The following is a description of a gene set: studied in species Homo sapiens Polymorphisms in nitrosamine metabolism, DNA repair, and immune response genes have been associated with nasopharyngeal carcinoma (NPC). Studies have suggested chromosomal regions involved in NPC. To shed light on NPC etiology, we evaluated host gene expression patterns in 31 NPC and 10 normal nasopharyngeal tissue specimens using the Affymetrix Human Genome U133 Plus 2.0 Array. We focused on genes in five a priori biological pathways and chromosomal locations. Rates of differential expression within these prespecified lists and overall were tested using a bootstrap method. Differential expression was observed for 7.6% of probe sets overall. Elevations in rate of differential expression were observed within the DNA repair (13.7%; P = 0.01) and nitrosamine metabolism (17.5%; P = 0.04) pathways. Differentially expressed probe sets within the DNA repair pathway were consistently overexpressed (93%), with strong effects observed for PRKDC, PCNA, and CHEK1. Differentially expressed probe sets within the nitrosamine metabolism pathway were consistently underexpressed (100%), with strong effects observed for NQ01, CYP2B6, and CYP2E1. No significant evidence of increases in rate of differential expression was seen within the immune/inflammatory pathway. A significant elevation in rate of differential expression was noted for chromosome 4p15.1-4q12 (13.0%; P = 0.04); both overexpression and underexpression were evident (38% and 62%, respectively). An elevation in the rate of differential expression on chromosome 14q32 was observed (11.3%; P = 0.06) with a consistent pattern of gene underexpression (100%; P < 0.0001). These effects were similar when excluding late-stage tumors. Our results suggest that nitrosamine activation and DNA repair are important in NPC. The consistent down-regulation of expression on chromosome 14q32 suggests loss of heterozygosity in this region. Genes down-regulated in nasopharyngeal carcinoma (NPC) compared to the normal tissue. Human Gene Set: DODD_NASOPHARYNGEAL_CARCINOMA_DN from publication Dodd LE, Sengupta S, Chen IH, den Boon JA, Cheng YJ, Westra W, Newton MA, Mittl BF, McShane L, Chen CJ, Ahlquist P, Hildesheim A (PMID 17119049), and this is the list of marker genes: ANKMY1, OR7E12P, UBL3, ADIRF, CFAP119, DNAH9, CIMIP2C, MRAP2, MAP6, SPA17, SCRN1, DNAH3, KRT4, RUNDC3B, SMIM22, PPIP5K1, TTLL10, TMCO6, CDC14A, ATP6V1D, LINC02288, DNAH1, COL1A1, DRC3, TUBBP5, DND1, ST3GAL3, CDC42BPB, DDAH2, ARMC3, PLAC4, PARVA, CRACR2A, PLEKHH1, CCDC69, SPTLC2, SGSM3, SLC13A4, TACC2 (transforming acidic coiled-coil containing protein 2), TP53INP2, TOM1, CLDN3, KCNJ15, NATD1, CD1C, GCHFR, SDCBP2, MINDY1, GRIN3B, RMDN3, TCP11, PKN3, CEACAM6, CHMP1A, CPPED1, CFAP73, KLHL6 (NCBI Gene Id 89857), ANKUB1, MYEOV, LINC01222 (NCBI Gene Id 102800316), AQP5, ATP6AP1-DT, CLMN, CD22 (NCBI Gene Id 933), TSNAXIP1, LRRC18, CIRBP, DUOX1, SLAIN2, CATSPER2, RNH1, PHYHD1, PRKAA2, SHLD1, LINC01821, RORB, ZBTB14, CRYBG2, MMP24, CERT1, CIMAP1B, DNALI1, FAM131A, NIPAL2, AGFG2, SAT1, CCDC13, YIF1B, KCNJ12, MTSS1, PGAP3, DEGS2, TMEM45B, KRT23, ARHGEF37, ADRB1, BCAR1, CLIP4, CIMAP3, POMGNT2, TPO, CFAP43, TPPP3, CRACDL, MPRIP-AS1, GPR162, SMIM6, PSKH1, PPIL6, TRMT44, CTSB, FAM149A, RDH10, IGHG1 (immunoglobulin heavy constant gamma 1 (G1m marker)), GOLGA2P5, C22orf23, GGT7, ALB, VAMP5, NBL1, ROPN1L, FKBP1B, EPPK1, LIAT1, CAND2, MAP1LC3A, TPRG1L, AFDN, CDC20B, CAMKK1, JDP2, CCDC181, SLC22A16, MSRA, ELF3, CXCL17, TPTE2P6, ZDHHC13, BCL2L15, GALNT14, POLR1HASP, RECQL5, MNS1, ATP6V0A4 (ATPase H+ transporting V0 subunit a4), GIRGL, FGF14, RASSF1, COQ4, PGM5-AS1, LYPD6B, NHERF1, VNN3P, SYTL1, VPREB3, UBTF, LRRC56, MYH4, TTC23L, MACROD2, DALRD3, ZNF703, MLPH, LINC00899, VILL, INAVA, STOM (NCBI Gene Id 2040), SNTN, APLP2, TNFAIP8L1, ZNF839 (zinc finger protein 839), MAOB, TBC1D22A, ENSG00000290731, PRSS22, BLID, CFAP126, IQUB, DIAPH2, C2CD4D-AS1, ENPP5, MLYCD (malonyl-CoA decarboxylase), TBC1D10A, CLEC4F, PPOX, CEP19, CYP2E1, YPEL3, GRM5, MIPEP, ABCA13, ABCC2, ARK2N, ATOSA, LRRC10B, IP6K1, STRBP, SMPD2 (NCBI Gene Id 6610), NSUN7, SCAMP2, CC2D2A, MUCL1, MEIS3P1, ANKRD9, CELF6, LYPLA2, OGG1, FUT2, ZNF445, GPT2, REEP6, EPHA2, LRRC27, SUSD6, PCDH1, USP4, WFDC21P, CAPN5, CBX7, PDZD2, SPRR1A, DEFB124, GAS8, CYP2F1, WDR17, CYSTM1, MUC4, SERTAD4-AS1, DHRS9, SPAG16, CFAP157, GJB1, ZC2HC1C, DMRT2, KALRN, CCDC190, CKMT1B, GIPR, CFAP46, ZNF542P, CD72, LINC00683, FARP2, ZNF844, TEKT1, HOPX, TMC5, MPL, USP51, ENSG00000280119, OSBPL6, WDR93, WWP2, SHANK2, LINC00963, CES1, BDKRB2, PAPOLA, KIF19, STOML3, SYTL5, STK11IP, C21orf58, WFDC2, LY6G6E, CWH43, FBXL8, ABHD2, LINC01770, ING2, CFAP95, CFAP47, NUP50-DT, DIO1, NR4A2, TTC6 (tetratricopeptide repeat domain 6), TREML2, MSANTD2-AS1, ARRDC2 (NCBI Gene Id 27106), NIPSNAP3B, IFTAP, ARSD, DIXDC1, TLE2, NINJ2-AS1, ARHGAP32, LIMK2, TSPAN6, SLC34A2, TMPRSS11D, SLC37A1, CCDC78, ZNF487, NEIL1, C16orf89 (chromosome 16 open reading frame 89), DNAH7, CEP164, SLC51A, CCDC12, RNU4-78P, MBTPS1-DT, CA5B, ATP2C2, SHISA8, ENSG00000258752, SERPINB3, MSLN, SPATA24, CLDN7, SERPINB2, PDLIM2, DELE1, TMEM154, OSBPL10, PDZK1IP1, FAM174A, MS4A15, FCMR, GSTA1, CD163L1, DUSP1, STARD9, CCDC80, HSBP1, MDS2 (NCBI Gene Id 259283), DNAH11, DAW1, MAP3K13, CFAP276, HSPB8, BTD, ENSG00000308109, NME5, OR2A4, PSENEN, EFHC2, HS3ST6, STX18 (syntaxin 18), TMEM120A, FBXL7, SYTL2, BACE2, ANXA1, DYDC2, NEBL-AS1, B3GALT4, TTC39C, BEND5, RASAL2, TTLL13, KRT40, WDTC1, APCDD1, SORT1, DNAH5, TMEM125, CTH, MMP15, CFAP298, DCTN1-AS1, LINC00592, ENSG00000271046 (novel transcript), TTC9, GAN (gigaxonin), TBC1D9, TNNC1, NHLRC2, FBXO36, EPS8L2, ASAP3, NIBAN3, CSTB, RIPK3, TEKT2, TMEM107 (NCBI Gene Id 84314), CCDC157, PNLDC1, C11orf97, DNASE1L3, PKHD1L1, CD55, NMU (neuromedin U), ALOX15, LINC02622, SLC16A5, RNU6-418P, S100P, ENSG00000238142, FCRLA, SIX2, SRD5A3, FOXN3, SPACA9, FAM153CP, SNORD123, MRPS31, CD180, SLC20A2, MAB21L4, CLDN10, CFAP45, CCDC60, ADGB, CMAHP, GOLGA2, RIIAD1, PAPOLA-DT, PCYT2, VTCN1, CHST9, KATNIP, WDR49, VWA3A, GIHCG (NCBI Gene Id 100506844), SEPTIN5, SLC16A7, SAXO4, RALGAPA2, MB, ADHFE1, HEY1, ZFYVE21, BCO2, TRIM7, KLHDC8B, CGN, HHLA2, SLC44A4, POLD4, KHDC1L, RINT1, C11orf71, STN1, SSUH2, HIPK1, CIZ1, MKS1, CFAP206, STK33, TMCO5A, VSTM2L, GPR182, PRUNE2, SYNE4, DNAJB2, ABCB1, CFAP74, EFCAB6, ZBBX, CH25H, CIB2 (NCBI Gene Id 404086), IFFO2, B9D1, NECTIN4, DCDC2B, TFF3, UNC5B-AS1, SPAG1, ACSM1, MAGED2, SCGB1A1, BICDL2, GNMT (glycine N-methyltransferase), S100A6, BAIAP2 (BAR/IMD domain containing adaptor protein 2), OR2A1-AS1 (OR2A1 antisense RNA 1), EPAS1, SLC16A9, DNAH10, CCDC146, SELENBP1, PGAP4, CHL1, KRT13, SH3D19, SAXO2, TMEM61, TMEM190, PLCE1, CDHR3, CFAP53, RABL2B, CHST6, SMPD3, CYB561D2, CARD14 (NCBI Gene Id 79092), KRT78, EFHD2, DENND6B, TEX26, P2RY2, CCDC88C, RHOBTB2, SYNE1, DNAH2, ARX, H2BC21, SPATA7, FOCAD, GSN, FAM216B, C15orf62, EIF4EBP3, AK9, ADSS1, CD79B, PPDPF, SLC46A3, TRIM55, DNAI3, LGALS7, CCDC148, TRNP1, C4BPB, DYDC1, LXN, ANKRD35, KLK10, WDR31, CALM1, EZR, PER1, TNFSF11, TMF1, SLC27A1, CASP9, SAP25, SAA1, KLHL41, SGMS2, MAK, PTPRO, MTF1, KRT80, ZNF667, AHNAK2, CIPC, VPS11, CLCA4, MICAL3, ME3, CPLX3, CD81-AS1, MMP24OS, CES4A, EXD3, ZNF439, SPATS1, AGBL4, LDLRAP1, SPINK2, PINK1 (NCBI Gene Id 65018), CXorf58, SPMIP6, CCEPR, GSTA3, DEF8, HEMK1, ALDH1L1, LINC00326, PDCD6IP, SYNPR-AS1, ASXL3, IL5RA, TAX1BP1, AGBL2, TRPM1, TNXB, KRT7, TNFRSF10D, UCP2, EPB41L4B, RHOU, C2CD2L, CYP2A6, CLIC6, HDAC5, ZNF295-AS1, CEACAM7, ALS2CL, CNGA4, EFCAB12, ASL, ENSG00000237773, DCST1-AS1, TM7SF2, PI3, SLC2A10, GNAQ, MASP1, DNAI2, DNAJA4, RGS14, ARG2, SMIM34 (small integral membrane protein 34), MYH11, ANXA2P2, CFAP221, ST6GALNAC1, TCEAL3, HOTTIP, SAMD15, NPHP1, CEP112, KLF8, IQCH, LRWD1, STIMATE, MGAM, IYD, TTC12, SPATA17, B3GALT5 (beta-1,3-galactosyltransferase 5), DNAAF1, SPAG8, CAPN9, SCUBE2, REEP1, PHACTR1, FAM153A, RGS8, PSMB8-AS1, E2F4, ZBED5-AS1, MOK, NEBL, STEAP4, AXDND1, OXTR, GDPD3, SNRK, PPP1R36, B3GNT7, TMEM256, SLC12A6, ACTL7B, SAPCD1-AS1, TCTN1, SUGT1P3, FAM209B, RPS6KA2, PLEKHS1, CAPN14, GFOD2, SYBU, ENSG00000253887, CAPS, DNAH6, RARB, SAT2, HFM1, LOXL4, CDKL1, FAM107B, IMPA2, LMO7, MFSD4A (NCBI Gene Id 148808), PTGDS, DCDC1, OR7E14P, RRAD, CCDC170, SLC24A4, CFAP61, UGCG, BCAS1, PLLP, AGR3, PIAS2, PIH1D2, LRRC4, ODF2L, IL18, EHD3, ZFAND2B, GSTZ1, WDR13, CROCC, PIP4P1, CLUAP1, ZNF214, ADH6, ATP13A4, PCP4L1, LCN2, RIBC1, NRXN3, MPHOSPH6, AHI1-DT, CETN2, KLK13, BACE1, RNF183, FECH, KCNMB2, LRRFIP1, LRGUK, TXLNB, BASP1, BDH1, CLDN8, RSPH1 (NCBI Gene Id 89765), MST1, TMEM40, WDR86-AS1, PYGL, LEFTY2, ACRBP, RIBC2, WFS1, PIAS3, MS4A1, DUSP22, SAA4, DYNLT5, MUC5AC, DZIP3, ABHD17B, DNAAF6, OR7E47P, DUSP26, ZSCAN31, HHATL, PPP1R16A, AGPAT2, PDE7B, GLIPR2, DENND2C, MVP, FMN1, IRAG1-AS1, SLC15A2, PRSS23, GLUL, MUC16, RSPH10B (NCBI Gene Id 285927), HECTD1, GOLPH3-DT, ELK3, TSGA10, GAPVD1, VWA8-AS1, NIBAN2, ARMC2, MOB3C, TPT1, POR, ALCAM, LIPH, PLAAT4, CKB, OR2A20P, CFAP210, TOGARAM2, CAPS2, ENSG00000265246, STAG3, ANKRD54, MAGIX, RNF103, PRRT3, C6orf132, PPP1R3C, MAP3K1, CCDC89 (NCBI Gene Id 220388), ABCC6, BCAN, METRNL, EPB41L1, RPSA2, ZNF784, BHLHE41, TMEM105, EVPL, KCNK6, DRC7, TSPAN1, CFAP69, ZSWIM5, QSOX1, CFAP58, GNAL, EFHB, LRTOMT, GRAMD1C, EFCAB2, NR2F2-AS1, POLR2A, ANKFN1, REXO1, PZP, CIITA, CFAP263, CADM4, MEIS1, FAM219B, MROH8, SORBS2, C9orf152, FBXL2, ZNF662, CRAT, DRC1, CYP2C8, ATP1A2, SMBD1P, SH3BGRL2, UST, ANKRD18A, MT1M, AKAP13, MDH1B, RSPH3, EXPH5, RHOV, PRR15L, C7orf57, LRRC23, POM121L4P, IGSF22, CDH12, MSI1, ZNF677, CALML4, BTBD7, MZF1-AS1, ZNF552, FAM184A, ZNF106, DICER1-AS1, ANXA9, CEP170B, RAB38, TMC4, DYNC2H1, IL20RB, DYNLRB2, CFAP92, BBOF1, SLC25A14, SERPINB6 (serpin family B member 6), MBOAT2, MEIS2, CLCN4 (NCBI Gene Id 4412, chloride voltage-gated channel 4), DMKN, MKX, BMPR1B, DUOXA1, CHP2, PCSK5, IFT46, ADORA1, ENSG00000270159, CCDC30, KCNE3, DOCK8-AS1, DTX4, RAB40B, DNAI7, FBLN7, P2RY1 (purinergic receptor P2Y1), SLC22A4, AMOTL2, BTG4, PCDHA9, BLK, CBY1, MAP1A, SPAG6, HMGCL, MYCBPAP, C6orf118, RIPOR2, FUT8-AS1, PPP1R13L, VPS9D1, EYA4, PEX11A, CASC2, FKBP6P2 (NCBI Gene Id 541473), LINC02846 (NCBI Gene Id 105376323), NEK11, PTPRT, ZNF599, ATP10B, TTC38, CIMIP6, TNS1, FUT6, JADE1, P4HTM, ADGRF1, PLEKHG2, DOP1B, SLPI, DIDO1, SPATA18, GNG7, ZER1, C4orf3, SYTL4, ACSBG1 (NCBI Gene Id 23205), CHRNA3, MYH14, RGS22, ADAMTS8, TMEM156, USP2, SMIM5, MYO1D, PXN, ERBB2, ZNF474, C22orf15, MBP, THRB, ST14 (ST14 transmembrane serine protease matriptase), ARMH4, CFAP96, ENSG00000235659, PER2, TTC7A, ZDHHC1, SLC22A18, PPARG, SERHL, VSIR, MYO5B, PINLYP, LZTFL1, PRDX1, SRPX2, DNER, CRIP1, ECM1, CA12, MLF1, FAXDC2, PTPRU, ADH1A, FRMD4B, PRKCD, MMEL1, LINC00939, EP300-AS1, PLXNB1, BBS9, CFAP107, NRAV, IFT56, CCDC39, NUMB, C15orf48, PTGR1, LPCAT4, DZANK1, SH3GL3, KIAA0513, TNFRSF19, CD19, IQCA1, SIX1, PCBP3, CCDC136, SERPINB4, FOXP1, SERPINB13, WFDC3, FAM83E, OSBPL2, ANKRD37, GNA11, DUOX2, RTEL1, FBXO34, CR2, ABLIM1, SNRPCP11, GRHL2-DT, MIR34B, MED16, SLC25A29, PLPPR3, TJP3, PITPNM1, C1orf87, MAP4K3-DT, MYZAP, FAM221A, SVEP1, GBP6, SCGB2A1, CACFD1, C10orf67, TTTY8, CPEB3, PHF1, ELL3, STK32C, TIMP4, CXXC5, GSKIP, HES1, ALDH1A3, CRY2, NFE2L2, IL20RA, GNE, HHEX, FAM229B, UPK1B, LCA5, CD1D, DHCR24, CCR6, UBAC2, KCNT1, FANK1, ASRGL1, SIGIRR, PIERCE2, PLAAT2, TCL1A, TMBIM1, GRK6, STIM1, ENSG00000293607, STPG1, ENKD1, RNF175, ZDHHC3, SERPINB1, TOR4A, GMDS, PITPNM3, OMG, MARCHF10, COL25A1, CFAP251, GNA14, MYOF, TPPP, ADARB2, CYP39A1, EIF1B-AS1, SPIRE2, RHPN2, SLC13A3, ZNF750, CFAP184, DGKD, MOSPD3, DNAJB13, CYP2B6, SLC6A6, ADH1C (NCBI Gene Id 126), CTNS, CFAP70, NT5C2, STK24, CCDC17, ZMYND10, STPG3-AS1, GPD1L, MAL, TGM1, ZNF185, PCDH20, LINC03086, ZNF853, ABLIM3, TADA2B, TSTD1, CFAP410, ALDH3A2, TUBB4B, DRD2 (NCBI Gene Id 91906), FBXO15, RALGPS2, SUNO1, LINC01186, ALDH3A1, SPATA4, ENTPD3, GUCY2C, DLEC1, CCL28, LINC00856, VSIG2, PIGR, CYB561A3, KLHDC7A, CACNA1I, CABCOCO1, NEK5, CFAP300, KATNB1, KNDC1, DHX32, FRAT1, LINC00467, KRT14, TIPARP-AS1, ROPN1, FCRL2, SLC35C1, CCDC160, ESPNL, IDNK, KLF5, DBP, CFAP91 (NCBI Gene Id 89876), PRKAR1A, DYNC1H1, TIRAP, C6orf89, ZNF709, LEKR1, DNAI4, DNAL4, RORC, DNAAF11, CFAP20DC, AMFR (autocrine motility factor receptor), GALC, KLHL32, DZIP1L, RAB37 (RAB37, member RAS oncogene family), DUSP18 (dual specificity phosphatase 18), WNT9A, CRACR2B, TRAF3IP1, IFT43, PLAC8, CIMIP1, CEACAM5, ABHD14B, SIK3, SPATA6, RBM20, AMIGO1, CLIC5, EPS8L1, DGCR2, VMO1, RBM24, CD40LG, CATSPERE, FAM90A1, RNASE4, ABHD12B, H2AC8 (H2A clustered histone 8), CST6, CAMK2G, SERTAD4, MIEF2, RORA, CLIC3, ZNF473CR, CCN2, TACSTD2, ZNF667-AS1, VTN (vitronectin), GCLM, ITPK1, MIR141, ZNF880, FGD2, CRYM, TCEA3, NAPRT, SCRN2, CPQ, PHLPP1, AHNAK, ENKUR, PWWP2B, KCNE1, OSCP1, BTC, RPS6KA3, DYNLT1, KCNQ1OT1, CYP4B1, NEK10, NF1, CBFA2T3, TRAK1, CNKSR1, PRKAR2A, TENT5B, AQP4, KLK12, BAG1, TTC16 (tetratricopeptide repeat domain 16), LITATS1, FCER2, NFATC1, ATL1, FRMPD2, ODAD3, UBXN10, TECPR2, CIMIP2B, CLU, ODAD4, LRRC71, HYDIN, SETD3, FAM174B, C4orf19 (chromosome 4 open reading frame 19), ASS1, AQP3, BAG5, PTPN21, CCDC40, LRRC73, SPNS3, F3, SMIM2-AS1 (NCBI Gene Id 101929212), ASIC1, OSBPL7, KAZN, BEST4, ABCA8, VPS37B, PRR29, TOX3, STK40, WDR26, CCDC65, SEL1L3, SLC6A11, BPIFB1, YIPF2, LINC01127, DOCK9, SLC41A3, LINC01732, SLC9A1, TMEM72, ADH7, MAILR, UGT1A10, R3HDM4, ZBTB7A, GCNT3, ERICH3, GALNT4, GK, MUC20, KAT5, GABRP, RIPK4, MARCHF4, LTF, TMEM67, PLIN3, FOXA3, CRYZL2P (crystallin zeta like 2, pseudogene), KIAA0319, C2orf81, CYSRT1, TMEM254, RCAN3, FAM107A, DPP10-AS1, MORN2, C9orf72, TRIM29, WASHC2C, LRRC34, FHL1, PRDX5, ZNF20, MAP2K3, PPP6R1, CAMSAP1, SCNN1A, ADGRE3, MAPK8IP1, SPEF1, ZNF395, WWC1, FOLH1, PKLR, RASGRP2, C19orf33, CFAP99, IK, H2BC4, TEKT3, COL28A1, LRRC43, YPEL2, ARHGEF26-AS1, TMEM8B, KIF13B, PRMT8, RCSD1, CHD9NB, LRRC8A, SPRR3, MTMR12, EML2, ORAI2, TGFB1 (transforming growth factor beta 1), LAYN, ARHGAP18, TSLP, FCRL4, TRIM13, IFT57, CXCL1, AK7, BAP1, B3GNT6, EML6, MIR449A, TMEM232, RFX2, ZBTB38, MEF2C, EPN3, COBL, IRAK2 (interleukin 1 receptor associated kinase 2), NACAD, AADAT, MYCBP, TMEM121, ZFP36, ABHD5, ENPP4, INHBB, DDX28 (DEAD-box helicase 28), TCTA, ADRA2A, NLRX1, ITGB8-AS1, CCNO, VWA3B, CRNN, ILRUN-AS1, FOXJ1, CCDC33, TTC29, CDKL2, CFAP161, SRD5A2, ZNF204P, WDR55, AKAP14, PTPRN2, SECISBP2L, PACRG, NIPAL3, PSPN, CP, RPTN, LLGL2, GPRC5C, IGHD, LINC00528, EMC3, PROM1, C5orf63, CMTM8, SMIM14, TSPAN3, STX7, ST6GALNAC6, RAB11FIP1, BAALC, TUSC2, DNAL1, CFAP90, MAPK3, MUC12-AS1, C8orf34-AS1 (C8orf34 antisense RNA 1), SCEL, DEUP1, GORASP1, LINC01354, CFAP299, FAM86C1P, GIPC2, TPTEP1, VIPR1, ODF2, ANXA11, C5AR2, PITPNA, MAP3K19, IFT140, TPCN1, ZCWPW1, ADH1B, OCEL1, CHMP3, SEC14L3, PRR15, KCTD11 (potassium channel tetramerization domain containing 11), RBKS, SEC14L4, LRG1, ENSG00000181123, TMPRSS2, ZNF396, USP19, RUNX1, CSTF2, SPEF2, IFT88, TNFRSF21, MED11, GPRIN2, CDK20, ACOT8, NBEA, SPNS2, TCTN2, SNX31, RAB36 (RAB36, member RAS oncogene family), DUBR, CDHR1, FNDC11, GALNT5, NHSL3, DNAH12, TMEM184A, SYNGR1, TNRC18, SLC27A6, SERINC2, TMEM50B, ALDH1A1, KDM7A, SLC17A1, CPEB1, MTFR1L, SNX22, MSMB, PROCA1, TTLL9, POU2AF1, MGLL (NCBI Gene Id 152009), TK2, DNAAF4, CNPPD1, SPOCK3, ATP2A3, SHISAL2A, H2AJ, GAS2L2, LRRIQ3, SLC26A2, LCA5L, FBXL13, LINC01857 (NCBI Gene Id 102724714), GDPD5, CATSPERD, NUP214, CLBA1, RAB17, TTC39B, SPATA33, C11orf52, SCIN (NCBI Gene Id 85477), ZBTB7C (NCBI Gene Id 649379), SPG7, CYB561, AFF3, WLS, SERPINB11, FBXW9, VWA5A, WASIR1, NDRG2, PLS1, WDR54, RAET1E, SMAGP, EPPIN, KLHL14, FCRL1, ZMYND12, TLCD2, PRSS27, MIDEAS, EDAR, MYCT1, CKM, IFT22, PPP1R12B, MT1E, BTBD6, FGGY, HACD4, BBS4, IQSEC1, SWSAP1, KIF9 (kinesin family member 9), MAGOH-DT, IQCG, ZNF19, APCDD1L-DT, MSI2, PIK3C2B, VSIG10L, FHAD1, RSPH9, ALDH3B2, CES2, UNC13B (unc-13 homolog B), LRP10 (LDL receptor related protein 10), ERICH5 (NCBI Gene Id 203111), RSPH4A, CASZ1, ATP12A, RERE, PCDH9, NQO1, TTC21A, B3GNT4, FMO2, B3GNT9 (NCBI Gene Id 84752), FBXW10B, CRYL1, RXRB, BTBD9, MANSC1 (MANSC domain containing 1), LRRC46, CCNA1, ZBTB42, KLHL3, PALMD, PTPN3, APOBEC4, HRK, CCDC74A, LRP2BP, CFAP65, EPN2, STS, CLDN23, LINC00926, ODAD2, FAM3D, PIK3IP1, MPP7, SUN1, TUBA1A (NCBI Gene Id 95407), PAQR7, EEIG1, SCARA3, GALE, PXK, MROH9, RUNX1T1, SOBP, PLEKHA6, CNN2, FA2H, SLC27A2, CDS1, PEX11G, WRAP53, PTK6, RASAL1, ATF7IP2, CD59, CEP126, CAPSL, FHL2, CA6, MINDY4, MAGI3 (NCBI Gene Id 57725), NFX1, PRKCZ, LINC01697, MUC13, ECRG4, DRC12, ENSG00000309434, EFEMP2, CASP7, DHRS3, CYP2B7P, DCAF5, FYB2, CASTOR3P, MS4A8, MYL12B, FAM81B, SLC27A4, LINC02363, ZNF582-DT, USP43, MISP, SPAG7, DNAAF3, RRN3P2, PDXP-DT, MORN5, C8orf34 (NCBI Gene Id 116328), KLHDC9, ARNT, TMPRSS11B, TOLLIP, KCNJ16, SUGT1P4-STRA6LP-CCDC180, LPAR5, SNX29, GPX8, CIMIP2A, GON7, C11orf16, EBF1, GALNT12, CFAP44, PLA2G10 (phospholipase A2 group X), RHBDL2, MED15P9, C6, MUC1, S100A9, COX7A1, CCDC103, SLC6A14, GLB1L, SPINK5, GRHL3, EYA1, SARM1, MAGI1, MCU, ODAD1, CFAP52, IFT172, LINC01737, DNAI1, IFITM10, H2AC18, KLF2, LRP11, JRK, VAMP8, PAX5, MAJIN, RAB43 (RAB43, member RAS oncogene family), TMEM220, ABHD15, LYN, HOATZ (HOATZ cilia and flagella associated protein), PADI1, SFMBT1, SSBP4, TUBB2A, GPR160, EVA1C (eva-1 homolog C), WEE2-AS1, CAST, CIB1, CD200R1, AFDN-DT, PTPRH, ADCY2, NEDD4L, SDR16C5, NFIA, IL22RA1, HSD11B1L, ZC3H12A, SMDT1, IGHM, TUBA4B, BNIPL, TMPRSS3, EPIST, OTUD1, PRR18, ABAT, IQCD, AMY1A, NUDT7, EFHC1, MALL, HSD17B8, ERGIC1, MRLN, FAM83A, MYORG, CR1, FYCO1, FAM27E3, NRAD1, ABHD6, FGF14-AS2, WDR38, TRIM41, NUCB2, GPC1-AS1, KCNB1, CNFN, GSDMC, KATNAL2, RHCG (NCBI Gene Id 51458), MORN3, KDM7A-DT, TMPRSS4, KLRB1, ARMH1, PDCD4, PIERCE1, SPATA6L, BAIAP3, METTL27, SIPA1L1, AKR1C3, SERPINB7 (NCBI Gene Id 8710), IDS, H19, GGT6, FMO5, LYL1, TMEM231, LGALS3, LINC02303, GRM7, CTNNA1, TNFRSF14-AS1, PNKD, EXD2, IGHA1, INPP5A, FLRT3, TMEM213, ULK4, COQ10A, NUDT16L2P, NOXA1, PHEX, TMEM25, CLEC4GP1, ITPKC, PHF7, MEIG1, KIF21A, DCDC2, A4GALT, GDA, REC8, GULP1, KCNQ1, CCDC81, HOMER2, GPRC5A, CDH26, PPL, AGR2, SASH1, AK1 (adenylate kinase 1), VPS13D, RALGPS1, PPP2R5A, MFSD6, FILIP1, BCL6, DLGAP1-AS1, LIN7B (NCBI Gene Id 64130), LMO2 (NCBI Gene Id 8051), KIAA1614, AP1M2, TMEM53, SCNN1B, SVOPL, FHDC1, NXF2, C1orf116, TNFRSF13C, CCDC187, WDR25, USF3, ANKRD45, NEXMIF, TMED10, IKBKB, ANXA2 (annexin A2), SPDEF, FUT3, TEX264, ALDH3B1, DLGAP4-AS1, SNED1, SPAG17, GFOD3P, GDF15, KLK11 (kallikrein related peptidase 11), ARHGAP39, ZKSCAN2-DT, CFAP100, LNX1, RPL10, TMEM234, LRRC36, MAP3K9, LINC00402, TNNC2, HLF, PLBD1, TUBA4A, SLC9C2 (NCBI Gene Id 284525), MPZL3, RSPH14, B3GNT3, FGF9, KIF6, LINC02345, PRDM9, TTC22, TSHZ2 (teashirt zinc finger homeobox 2), ATG9B, CLXN, JHY, THRA, ENSG00000291063, C7, JMJD1C-AS1, SRGAP3-AS2, TTLL5